The following is a description of a gene set: species: Mus musculus Mouse Gene Set: GOBP_T_HELPER_1_CELL_CYTOKINE_PRODUCTION Any process that contributes to cytokine production by a T-helper 1 cell., and this is the list of marker genes: Il12b, Xcl1, Arid5a, Slamf1, Tbx21, Il18r1, Il1b, Il18, Il18rap, Il12a, Il1r1